The following is a description of a gene set: studied in species Homo sapiens Neighborhood of SOD1 superoxide dismutase 1, soluble (amyotrophic lateral sclerosis 1 (adult)) in the MORF expression compendium Human Gene Set: MORF_SOD1 Neighborhood of SOD1, and this is the list of marker genes: DYNLL1, KXD1, ACOT7, FIBP, CDK4, VPS26A, SNRNP200, HAX1 (HCLS1 associated protein X-1), KHDRBS1, ACLY, ATP5MC1, MRPL3, RHEB, SSBP1, ATP5PF (ATP synthase peripheral stalk subunit F6), COX5A, POP5, RBMX, PUF60, GATD3, PSMD7, CNBP, ELOC, EIF4E2, PDHB, HADHB, POLR2I, ATIC, GANAB, TMBIM6, CLNS1A, TRAPPC3 (trafficking protein particle complex subunit 3), AHSA1, TMEM147, MRPL9, PPP2R1A, TARS1, SNRPA (NCBI Gene Id 6626), METAP1, HMGN1, COX6A1, ILF3, DRG1, NDUFC1, MTDH, G3BP2, SEC13, AKR7A2, CYC1, TPGS2, SRP9, UBAP2L, DCTN2, EIF3I, HNRNPAB, CCT7, HSPD1, STOML2, TOMM70, NDUFS1, NHP2, DGUOK, PSMD8, HSBP1, FBL, SNRPA1, EI24, RUVBL2, PSMB4, VDAC1, UBE2E1, SOD1, FUS, HDAC2, LSM4, SLC25A3, PARK7, NEDD8, DLD, CFDP1, ETFA, DHX16, XPOT, ATP5MC3, G3BP1, PSMB7, PRPF31, CS, CYCS, SF3B2, HSPA4, ACOT13, EIF2B4, PSMB2, UBE2L3, MDH1, ARF3, HCCS, NSDHL, PHB2, ATP5PD, NDUFV1, CCT5, XPO7, RARS1, HNRNPA3P1, ATXN10, BUB3, SLC3A2, H2AZ1, DOCK3, IFRD1, CCNB1, SLC4A2, NDUFB3, UNG, COPS5, STARD7, CCT3, SNRPE, SEM1, GGCT, CBX3, SRSF9, DDX49, SYPL1, RAD23A, PSMD9, TRIM28, CNIH1, PTGES3, FDPS, ENSA, MSH2, PTPN11, RPA1, DDX1, ATP5PO, TBCA, SMARCD2, PGRMC1, YWHAE, C6orf62, MRPS18B, HSPA8, PSMB1, AP2S1, MAGOH, PDCD6, ATOX1 (antioxidant 1 copper chaperone), LSS, TARDBP, C1QBP, PPP1CA, LYPLA1, PPP1R7, UQCRC2, NONO, SCAMP3, COA1, KARS1, LARP1, FEN1, GSPT1, MTA1, SSB, U2AF1, ALG8, RAN, POLE3, PSMA3, MFAP1, CCT2, ERH, SRSF1, EIF3C, KPNA2, FAM20B, AFG3L2, VBP1, PRDX4, COX7B, CDC123, HNRNPU, TMED2, CSNK2B, LSM3, LSM2, DARS1, SPCS2, TECR, ANP32B, PPM1G (NCBI Gene Id 5496), ZNRD2, ATP5F1D, BANF1, PSMC1, TAF11, FBXW11, NDUFAB1, NDUFS3, AIMP2, ANAPC5, DEK, SNRPG, KIF2A, TBL3, ILF2, HSPE1, AP2M1, CHERP, UQCRH, ATP5MF, UQCRB, MORF4L2, ZZZ3, CDC23, RAC1, UBA2, LRPPRC, MAML1, EIF4H, NME1, BCAP31, MTHFD1, EIF3B, CALM3, HNRNPC, YWHAB, MAP2K2, SEC61G, COX6C, HUWE1, MYL11, TUFM, HAT1, MPV17, RAD21, BZW1, PRKAR1A, PSMB6, NDUFS2, GPAA1, VDAC2, SMG7, PCLAF, CTDNEP1, GPN1 (GPN-loop GTPase 1), RAD23B, PSMA2, UTP18, SART3, COX4I1, EEF1E1, HSP90AA1 (heat shock protein 90 alpha family class A member 1), HNRNPA2B1, SDHA, PCNA, PSMA4, CANX, SET (NCBI Gene Id 6418), RTN4, SUMO1, NDUFS8, EBAG9, YWHAQ (tyrosine 3-monooxygenase/tryptophan 5-monooxygenase activation protein theta), PRPS2, SKP1 (S-phase kinase associated protein 1), TMEM106C, GLO1, NDUFS5, NDUFV2 (NCBI Gene Id 4729), NUDC, DAP, PRMT1, FAM120A, HSPA9, PRDX3